The following is a description of a gene set: species: Mus musculus The rough (or granular) endoplasmic reticulum (ER) has ribosomes adhering to the outer surface; the ribosomes are the site of translation of the mRNA for those proteins which are either to be retained within the cisternae (ER-resident proteins), the proteins of the lysosomes, or the proteins destined for export from the cell. Glycoproteins undergo their initial glycosylation within the cisternae. Mouse Gene Set: GOCC_ROUGH_ENDOPLASMIC_RETICULUM, and this is the list of marker genes: Aldob, Tmem97, Lyz1 (NCBI Gene Id 17110), Rps29, Ssr4, Pkm, F12, Sec63, Epm2a, Syne3, Rpl27, Hgfac, Uba1, Chil3, Suco, Epha5, Rho, Resp18, Lin28a, Srpra, Sec61b, Cdkal1, Rpn1, Rp9, Ptgds, Rpl18, Rps26, H13, Lyz2, Rpl6 (NCBI Gene Id 19988), Fkrp, Stau1 (staufen double-stranded RNA binding protein 1), Tmcc1, Lrat, Gnrh1, Sppl3, Plod3, Psen1, Maco1, Rps28 (ribosomal protein S28), Pi4kb, Rangrf, Sec61g, Zc3h12a, Plod2, Ccdc47 (NCBI Gene Id 97906), Sec61a1, Plod1, Edn1, Rps23, Car4, Myoc, Vtn, Rps21, Ckap4, Sec61a2, Rpl4, Hcrt, Srprb, Alg5, Rab14 (NCBI Gene Id 99047), Lrpap1, Arl6ip1